The following is a description of a gene set: This event has been computationally inferred from an event that has been demonstrated in another species.<p>The inference is based on the homology mapping from PANTHER. Briefly, reactions for which all involved PhysicalEntities (in input, output and catalyst) have a mapped orthologue/paralogue (for complexes at least 75% of components must have a mapping) are inferred to the other species. studied in species Mus musculus Reactome Pathway: Formation of the polybromo-BAF (pBAF) complex part of: SWI/SNF chromatin remodelers electronically inferred by orthology from the curated human pathway, and this is the list of marker genes: Smarcb1, Smarcd1, Smarcc1, Smarca4, Smarcc2, Bcl7a, Phf10, Bcl7b, Smarca2, Smarcd2